Given this list of marker genes TM4SF19-AS1, DYNLL2, DYNC2H1, MELTF-AS1, SMCO1, MIR4797, PIGX, PAK2, NCBP2, BRINP1, DYNC2I2, RABL2B, HFE, DYNC2LI1, DYNLT1, SLC51A, FBXW7, SDHAP1, MYCBP2, DYNC2I1, CEP19, STAT5B, DYNLL1, SIRT1, DLG1 (discs large MAGUK scaffold protein 1), TF, PIK3R3, WDR53, PIGZ, HIF1A, MYC (NCBI Gene Id 731404), HAMP, RNF8, MAD2L1BP, NCBP2-AS1, FNDC8, ZNF76, ZDHHC19, DYNLRB2, MELTF, DYNLT3, PIGM, SENP5, LINC00885, GRIA1, UBE2N, SLC51B, TGFB1, DLG1-AS1, NCBP1, NCBP2AS2, CASP7 (NCBI Gene Id 840), MCRS1, DYNLRB1, NF2, CEP43 (NCBI Gene Id 11116), TM4SF19, PCYT1A, H2BC21 (NCBI Gene Id 8349), NRROS, TFRC, UBXN7, JUN, PXN, RNF168, ADAM10, SLC40A1, STAT5A, CEP350, FBXO45, DYNLT2B, here is a description of the gene set: 3q29 copy number variation syndrome Human Gene Set: WP_3Q29_COPY_NUMBER_VARIATION_SYNDROME species: Homo sapiens